The following is a description of a gene set: Any process that stops, prevents or reduces the frequency, rate or extent of stem cell differentiation. Human Gene Set: GOBP_NEGATIVE_REGULATION_OF_STEM_CELL_DIFFERENTIATION studied in species Homo sapiens, and this is the list of marker genes: ZFP36L2, NOTCH1, JAG1, N4BP2L2, YAP1, TMSB4X, TBX3, ESRRB, BBS12, HNRNPU, TRIM6, PRICKLE1, STAT3, CDK13, HSPA9, YTHDF2, NELFB, HES5, NFE2L2, CDK12, EZH2, LBH (NCBI Gene Id 81606), REST, GSK3B, TCF15, HES1